The following is a description of a gene set: Human Gene Set: GOBP_EMBRYONIC_HEART_TUBE_LEFT_RIGHT_PATTERN_FORMATION The pattern specification process that results in the subdivision of the left/right axis of the embryonic heart tube in space to define an area or volume in which specific patterns of cell differentiation will take place. species: Homo sapiens, and this is the list of marker genes: NKX2-5, CIMAP3, PITX2, IFT122 (intraflagellar transport 122), CITED2, MEGF8